The following is a description of a gene set: Human Gene Set: HE_LIM_SUN_FETAL_LUNG_C0_EARLY_FIBROBLAST studied in species Homo sapiens Early fibro from publication He P, Lim K, Sun D, Pett JP, Jeng Q, Polanski K, Dong Z, Bolt L, Richardson L, Mamanova L, Dabrowska M, Wilbrey-Clark A, Madissoon E, Tuong ZK, Dann E, Suo C, Goh I, Yoshida M, Nikolić MZ, Janes SM, He X, Barker RA, Teichmann SA, Marioni JC, Meyer KB, Rawlins EL (PMID 36493756), and this is the list of marker genes: BCL11A, H2BC9, MAD2L1, SINHCAF, CKS2, H1-3, CENPU, SDC1, SERINC2, BAZ1A, GPC2, TENM3, CDC20, GPSM3, TOP2A, SCD, BID, CDCA7, IGF2BP1, LMNB1, MND1, MCM4, CDK1, NSG1, ORC6, ZNF93, KIF20A, RMI2, TYMS, CENPM, UBE2C, HMGA1, KRT18, MCM7, HNRNPA1L2, AURKB, CCNA2, HNRNPA1L3, SPC25, CENPN, PSAT1, MSMO1, NNAT, H1-2, HMGA2, CCNB2, CHAF1A, FBXO5, BIRC5 (NCBI Gene Id 332), PTTG1, H2AC14, AIF1, CTPS1, CRABP2, KPNA2, CENPF, CCNB1, ZWINT, CENPK, CDT1, RASL11B (NCBI Gene Id 79093), NUSAP1, UCK2 (NCBI Gene Id 7371), H2AC25, UHRF1, MKI67, FZD2 (NCBI Gene Id 2535), KRT8, TMEFF1, SNCG, SFRP1, GINS2, PIMREG, H1-1, HSPH1, CLSPN, UBE2T, CDCA5, UQCRHL, LIMD2, XIST